The following is a description of a gene set: Mouse Gene Set: GOBP_TRICARBOXYLIC_ACID_CYCLE A nearly universal metabolic pathway in which the acetyl group of acetyl coenzyme A is effectively oxidized to two CO2 and four pairs of electrons are transferred to coenzymes. The acetyl group combines with oxaloacetate to form citrate, which undergoes successive transformations to isocitrate, 2-oxoglutarate, succinyl-CoA, succinate, fumarate, malate, and oxaloacetate again, thus completing the cycle. In eukaryotes the tricarboxylic acid is confined to the mitochondria. See also glyoxylate cycle. studied in species Mus musculus, and this is the list of marker genes: Fh1, Aco1, Pdhb, Sdhc, Idh3a, Sdhd, Idh1, Ogdh, Sucla2, Cs, Idh3b, Idh3g, Idh2, 4933405O20Rik, Pdha1, Aco2, Sdhb, Dlst, Mdh1b, Pdha2, Col6a1, Sdhaf2, Suclg2, Ogdhl, Ndufs4, Mrps36, Dlat, Ndp, Sdha, Mdh1, Mdh2, Sirt3, Suclg1, Csl